Given this list of marker genes ICOS, PIK3CG, PIK3R5, PIK3CB, PIK3CA, PIK3CD, ICOSLG, PIK3R3, PIK3R1, PIK3R6, PIK3R2 (NCBI Gene Id 5296), here is a description of the gene set: studied in species Homo sapiens ICOS (Inducible T-cell COStimulator) is a critical costimulatory receptor that enhances T cell responses following initial activation. Unlike CD28, which is constitutively expressed on naive T cells, ICOS expression is induced upon T cell activation. Both ICOS and CD28 engage class IA phosphatidylinositol 3-kinase (PI3K), leading to the production of phosphatidylinositol 3,4,5-trisphosphate (PIP3) and activation of downstream signaling pathways, including AKT. However, ICOS signaling is distinguished by a stronger induction of PIP3 production and more robust AKT phosphorylation compared to CD28 signaling. This enhanced signaling through ICOS contributes to its unique role in promoting T cell survival, cytokine production, and differentiation, particularly in the context of T follicular helper (Tfh) cell development and function. Despite these similarities, detailed knowledge about ICOS-specific downstream signaling pathways remains limited, highlighting a key area for further research to fully understand its distinct and overlapping roles with CD28 in T cell immunity (Wikenheiser & Stumhofer 2016). part of: Regulation of T cell activation by CD28 family Reactome Pathway: Co-stimulation by ICOS